The following is a description of a gene set: studied in species Homo sapiens An increased volume of the endomysium, which is a connective tissue sheath that surrounds each muscle fiber. Together, bundles of muscle fibers form a fasciculus, surrounded by another layer of connective tissue called the perimysium. Human Gene Set: HP_INCREASED_ENDOMYSIAL_CONNECTIVE_TISSUE Increased endomysial connective tissue, and this is the list of marker genes: COL6A1, MAP3K20, MYOT (NCBI Gene Id 9499), TOR1AIP1, SELENON, CHKB, COL6A2, HMGCR, VRK1, CACNA1S, TTN, GIPC1, LAMA2, POMGNT1, TNPO3, MEGF10, TRIP4, ANXA11, SGCA, MYL1, ACTA1, COL6A3, SNUPN, SYNE1, ANO5, SLC12A6, HNRNPA1 (heterogeneous nuclear ribonucleoprotein A1), MLIP, CFL2, COL12A1, NOTCH2NLC, LARGE1, SGCG